The following is a description of a gene set: Egr2 is a transcription factor required for peripheral nerve myelination in rodents, and mutations in Egr2 are associated with congenital hypomyelinating neuropathy (CHN) in humans. To further study its role in myelination, we generated mice harboring a hypomorphic Egr2 allele (Egr2Lo) that survive for up to 3 weeks postnatally, a period of active myelination in rodents. These Egr2Lo/Lo mice provided the opportunity to study the molecular effects of Egr2 deficiency on Schwann cell biology, an analysis that was not possible previously, because of the perinatal lethality of Egr2-null mice. Egr2Lo/Lo mice phenocopy CHN, as evidenced by the severe hypomyelination and increased numbers of proliferating Schwann cells of the peripheral nerves. Comparison of sciatic nerve gene expression profiles during development and after crush injury with those of Egr2Lo/Lo Schwann cells revealed that they are developmentally arrested, with down-regulation of myelination-related genes and up-regulation of genes associated with immature and promyelinating Schwann cells. One of the abnormally elevated genes in Egr2Lo/Lo Schwann cells, Sox2, encodes a transcription factor that is crucial for maintenance of neural stem cell pluripotency. Wild-type Schwann cells infected with Sox2 adenovirus or lentivirus inhibited expression of myelination-associated genes (e.g., myelin protein zero; Mpz), and failed to myelinate axons in vitro, but had an enhanced proliferative response to beta-neuregulin. The characterization of a mouse model of CHN has provided insight into Schwann cell differentiation and allowed the identification of Sox2 as a negative regulator of myelination. Human Gene Set: LE_EGR2_TARGETS_UP Genes up-regulated in P14 nerves of transgenic mice having hypomorhic (reduced function) allele of EGR2. from publication Le N, Nagarajan R, Wang JY, Araki T, Schmidt RE, Milbrandt J (PMID 15695336) studied in species Mus musculus, and this is the list of marker genes: CADM1, RRM1, KIF23, ETS1, POU3F1, IQGAP3, LIN9, NCAPH, CDC20, RPA3, HNRNPA2B1, COL18A1, HDAC2, H2AZ1, MARCKSL1, CCND1, CDK1, CXCR4, BZW2, KLF10, USP1, FOXD3, CKS1B, LSM2, BASP1, CDKN1C (NCBI Gene Id 702), CDCA8, HMGA2, TOP2A, ECT2, COTL1, PSPC1, MCM7, JPT1, PDE8A, MCAM, SLC22A23, ATF3, SLC4A7, CCL2, NHP2, RPL13A, FIGNL1, CCNA2, TMX2, RBM3, KIF2C, NUSAP1, REEP1, CCNB2, CKS2, RRM2, EDNRB, PCLAF, CCNB1, RAD51, TENM3 (teneurin transmembrane protein 3), AURKA, UHRF1, SH3GL3, CHL1, BUB1, EZH2, P2RX4, H2AC8, KIF22, KIF11, EPHA5, UBE2T, PLEKHO1, LMNB1, SOX2, CXCL14, CORO1C, CIP2A, TNFRSF21, DNAJC9, RFC5, TNFAIP8, NAV2, BIRC5, TRIM59, EZR, TUBB6, SPECC1 (NCBI Gene Id 92521), PLK4, CUEDC2, MCM4, SMC2, CDC7, MARCKS, PPP1R14B, SPRED2, MCM5, H2AX, PRC1, TCF19, INCENP, CSRP2, MKI67 (NCBI Gene Id 4288), TNC, ID2, KPNA2, HMGB2 (high mobility group box 2), RBL1, MAD2L1, CD44, KIF20A, PLK1, NT5DC2